The following is a description of a gene set: from publication Zak DE, Andersen-Nissen E, Peterson ER, Sato A, Hamilton MK, Borgerding J, Krishnamurty AT, Chang JT, Adams DJ, Hensley TR, Salter AI, Morgan CA, Duerr AC, De Rosa SC, Aderem A, McElrath MJ (PMID 23151505) Genes down-regulated in peripheral blood mononuclear cell Ad5 nAb titers > 200 vs Ad5 nAb titers <= 200 in adults (20-50) (Ad5 nAb titers > 200) after exposure to MRKAd5 HIV-1 gag/pol/nef, time point 1D. Comment: Impaired up-regulation. Genes with MRKAd5/HIV-induced expression responses significantly impacted by Ad5 nAbs (24hrs). Table includes specific cell types. To better understand how innate immune responses to vaccination can lead to lasting protective immunity, we used a systems approach to define immune signatures in humans over 1 wk following MRKAd5/HIV vaccination that predicted subsequent HIV-specific T-cell responses. Within 24 h, striking increases in peripheral blood mononuclear cell gene expression associated with inflammation, IFN response, and myeloid cell trafficking occurred, and lymphocyte-specific transcripts decreased. These alterations were corroborated by marked serum inflammatory cytokine elevations and egress of circulating lymphocytes. Responses of vaccinees with preexisting adenovirus serotype 5 (Ad5) neutralizing antibodies were strongly attenuated, suggesting that enhanced HIV acquisition in Ad5-seropositive subgroups in the Step Study may relate to the lack of appropriate innate activation rather than to increased systemic immune activation. Importantly, patterns of chemoattractant cytokine responses at 24 h and alterations in 209 peripheral blood mononuclear cell transcripts at 72 h were predictive of subsequent induction and magnitude of HIV-specific CD8(+) T-cell responses. This systems approach provides a framework to compare innate responses induced by vectors, as shown here by contrasting the more rapid, robust response to MRKAd5/HIV with that to yellow fever vaccine. When applied iteratively, the findings may permit selection of HIV vaccine candidates eliciting innate immune response profiles more likely to drive HIV protective immunity. Human Gene Set: ZAK_PBMC_MRKAD5_HIV_1_GAG_POL_NEF_AGE_20_50YO_AD5_NAB_TITERS_GT_200_VS_LTE_200_1DY_DN studied in species Homo sapiens, and this is the list of marker genes: C1QC, BLVRA, CDKN1A, TNFSF10, NGFR, SDC3, CXCL10, ID1, MTHFD2, LINC00315, RTP4, OR3A3, PER1, CCDC180, KRTAP5-10, ABI3, C5AR1, FCAR, TLR7, LINC00092, IFI27, PTPRO, CXCL11, KLHDC8B, IGLV10-54, C1QB, P2RY12, SLC6A12, MIR1250, SNORA5B, CASP5, P2RY2, CLEC12A, VSTM1, SLC49A3, EPHB2, FAM25A, MS4A4A, CES1P1, CYGB, CES1, SERTAD1 (NCBI Gene Id 29950), LTF, NFKBIA, SEMA4A, ATF3 (NCBI Gene Id 467), CCRL2, CD300C, GPR84, TP53I3, PILRA, TRIB1, GPR141, MIR185, MARCO, RGL1, LILRB1, C3AR1, DDAH2, SMCO4, MAFB, CMKLR1, KMO, SNORA80A, DHRS7B, KIAA1958, NLRP3, CD300E, LGALS1, C2, SLC27A3, HBEGF, NOTCH2NLA, ATF5, CNIH4, ENSG00000282375, ANXA4, NSUN5P2, FAM225A, ZBTB21, CBR1, MERTK, ADM, TMEM255A, CLEC6A, TSPEAR-AS1, CFB (NCBI Gene Id 629), METRNL, HAVCR2, AKR1A1, SLC11A1, TMEM150B, SDHB (succinate dehydrogenase complex iron sulfur subunit B), CAMK1, KCTD14, SPRR2F, RRAS, GPBAR1, LILRA3, ASGR2, GPR35, NR4A1, AXL, CFD, CALML4, ASCL2, TCN2, CCL8, HK3 (hexokinase 3), SAMD4A, CYRIA